The following is a description of a gene set: ROBO receptors bind AKAP5 species: Homo sapiens Human Gene Set: REACTOME_ROBO_RECEPTORS_BIND_AKAP5, and this is the list of marker genes: PPP3CB, PRKACB, PRKCA, PRKAR2A, ROBO3, PRKACA, PRKACG, AKAP5, ROBO2 (NCBI Gene Id 90370)